Given this list of marker genes Rras, Nf1, Stap1, Bmerb1, Cers2 (ceramide synthase 2), Atp1b2, Idh2, Fas, here is a description of the gene set: Any process that stops, prevents or reduces the frequency, rate or extent of glial cell migration. studied in species Mus musculus Mouse Gene Set: GOBP_NEGATIVE_REGULATION_OF_GLIAL_CELL_MIGRATION